The following is a description of a gene set: from publication Nagar M, Jacob-Hirsch J, Vernitsky H, Berkun Y, Ben-Horin S, Amariglio N, Bank I, Kloog Y, Rechavi G, Goldstein I (PMID 20181891) Genes down-regulated in lymphocytes treated with TNF for 24h: T conv versus T reg cells. Here we show that tumor necrosis factor (TNF) induced in human T-regulatory cells (Treg), as compared to conventional T cells (Tcon), a transcription program highly enriched for typical NF-κB target genes, such as: the cytokines LTA and TNF; the TNF-receptor super family members FAS, 4-1BB and OX-40; various anti-apoptotic genes; and other important immune-response genes. As an initial approach to examine the cellular program induced by TNF in Tregs versus Tcon cells, we employed microarray gene expression analysis at 2 and 24 hrs following TNF treatment. species: Homo sapiens Human Gene Set: GSE18893_TCONV_VS_TREG_24H_TNF_STIM_DN, and this is the list of marker genes: MAPK4, FAAP20, PHTF2, COA5, DAND5, BPHL, TLR7, SMIM11, KRT10, RAD1, BIVM, ZNF638, IL16, RPS25, DNAH7, DTNB, ENO3, C22orf39 (NCBI Gene Id 128977), RAD9A, SIX4, ICE2, SLC9B2, MIEN1, THOC7, MARVELD1, CUTA, MAPK12, FUNDC1, ZNF692, C15orf40, GPRC5D, NLN, FAM13B, ZNF317 (zinc finger protein 317), CCDC28A, RPGRIP1, PFDN2, AKR1B1, NOXRED1, SESN1, ICE1, HCFC1R1, SCAMP1, NT5C, GPX1, CD83, TRIM32, LZTR1, ZNF81, CHCHD1, PRM3, ARHGAP20, UBE2D2, TRIM72, MFF, GALC, PDHA1, MRPS33, MCCC2, HSPE1, RPS11, GPRASP2, ZNF623 (NCBI Gene Id 9831), USP24, SMG1, HEXA, GUK1, SNRPG, DPM3, TIMM13, PPP1R11 (NCBI Gene Id 9160), TAF3, ZFAND6 (NCBI Gene Id 54469), ELP3, RPS21, MPP1, ZNF493, GPN1, MTSS1, MRM2, GRAP, RSU1, GPRASP1, NBDY, POFUT2, MLH3, MINDY1, PRMT3, MAP3K21, CDK10, NSFL1C, DNAAF10, SLC44A1, ATP5MF, GGH, OMA1, SLC30A3, HIVEP3, ARHGAP42, MRPS15, IRS4, HIBADH, SMC4, EBPL, ATP5MC2, NAXE, MRPL39, ALDOB, CNN2, DNAJC6, DCAF11, SP6, TSN, ST8SIA4, ZBED5, FOXO1, MAPK14, TIMM21, IER3IP1, POLE4, GABARAPL1, SOST, OSTC, NPAS4, THOC1, SIRT7, AIRN, MRPS21, RPL7L1, ADCY7, SCGN, EEF1G, DHRS7, C3orf80, USP53 (NCBI Gene Id 54532), OTULINL, CD320, UQCRHL, RWDD4, FAM162A, EEF1B2, LAMTOR5, LY9, RNF151, PAGR1, HOMER1, EIF4EBP1, LEAP2, TSPAN32, COTL1, STMN4, ZNF250, MASP2, NUMA1, CLCN2, C8G, MPC2 (NCBI Gene Id 25874), NUDT16L1, RAMP1, KCNQ1OT1, PTPN5, ARMCX4, CMTM6, RPS3, NDUFS6, B3GALNT2, CCT4, TACC2, EEF1AKMT1, ATP2C1 (NCBI Gene Id 612), MACROD1, GTPBP3, FUT1, MGA, IGF1R, ATG5, RFK, FAM32A, TOMM7, MOB1A, USP50, CDC26, DENND2C, ANKRD26, MTRR, HABP2, PLPP1, PDRG1, ZBTB44, DNAJC14, ZNF862 (zinc finger protein 862), ZMYM3, TNFRSF13B, TOP2B, NPM3, TMEM185A, MROH9, PRR13, COMMD7